The following is a description of a gene set: studied in species Homo sapiens from publication Schaefer CF, Anthony K, Krupa S, Buchoff J, Day M, Hannay T, Buetow KH (PMID 18832364) FAS (CD95) signaling pathway Human Gene Set: PID_FAS_PATHWAY, and this is the list of marker genes: SYK, MAP2K6, PIK3R3 (NCBI Gene Id 8503), MAPK8, BID, MAPK11, FAS, BTK, RIPK1, EZR, MAP3K1, BIRC2, IKBKG, PIK3CA, RFC1, PIK3R1, PIK3R2, FADD, CFLAR, MAP2K7, PIK3CD, CHUK, CLTC, FASLG, CASP10, MAPK10 (NCBI Gene Id 5602), SMPD1, MAPK14, SRC, MAPK9, PDPK1, CASP3 (caspase 3, NCBI Gene Id 836), PIK3CB, AKT1, CASP8, IKBKB, FAIM2, BIRC3